The following is a description of a gene set: Any process that activates or increases the frequency, rate or extent of lymphocyte chemotaxis. species: Mus musculus Mouse Gene Set: GOBP_POSITIVE_REGULATION_OF_LYMPHOCYTE_CHEMOTAXIS, and this is the list of marker genes: Il4, Tmem102, Stk39, Wnk1, Ccl5, Ccl21a, Ccl3, Ccr2, Wnt5a, Adam10, BC037156, Ccl7, Ptk2b, Oxsr1, Cxcl13, Tnfsf14, Xcl1 (chemokine (C motif) ligand 1), Cxcl14, Ccr7, Adam17, Nedd9